The following is a description of a gene set: part of: Virus Assembly and Release Reactome Pathway: Release Once the viral envelope has separated from the cell membrane Influenza virus particles are actively released to complete the budding process. HA (hemagglutinin) anchors the virus to the cell by binding to sialic acid-containing receptors on the cell surface. The enzymatic activity of the neuraminidase (NA) protein removes the sialic acid and releases the virus from the host cell. NA activity is also required to remove sialic acid from the carbohydrates present on the viral glycoproteins to prevent the viral particles from aggregating. studied in species Homo sapiens, and this is the list of marker genes: NS, NP, NA, PB2, PA, M, HA, PB1